The following is a description of a gene set: Mouse Gene Set: GOCC_STEREOCILIA_ANKLE_LINK_COMPLEX species: Mus musculus A complex of proteins that connect growing stereocilia in developing cochlear hair cells, composed of Vlgr1, usherin, vezatin, and whirlin., and this is the list of marker genes: Vezt, Adgrv1, Pdzd7, Whrn, Ush1c, Ush2a